Given this list of marker genes ADCY1, GNB3, GNB2, PRKAR1A, GNG8, PRKACA, ADCY5, GNG3, GNAI2, GNAI3, PRKACB, ADCY2, ADCY3, GNG2, ADCY9, GNGT2, GNAS, GNG7, GNAI1, SRC, SHC1, GNGT1, ADCY7, GNG12, GNG13, ITGB1, ITGA5, GNB5, PRKACG, ADCY8, GNG5, GNAT3, GNG10, GNAZ, PRKAR1B, ADCY6 (adenylate cyclase 6), GNG11, GPER1 (NCBI Gene Id 2852), FN1, PRKAR2A, GNB1, GNG4, PRKAR2B, ADCY4, GNB4, here is a description of the gene set: part of: G alpha (s) signalling events species: Homo sapiens Reactome Pathway: GPER1 signaling GPER1 (also known as GPR30) is an orphan G-protein coupled receptor that has been suggested to act as an alternate estrogen receptor. In support of this, a number of studies have shown that GPER1 stimulates MAPK and cAMP activation in response to estrogen in ESR1 negative breast cancer cells. Similar to classical ESR1-mediated signaling, this estrogen-responsive GPER1 is suggested to act through G beta gamma and to involve EGFR transactivation.